Given this list of marker genes KRAS, HRAS, SOS1, GRB2, SOS2 (NCBI Gene Id 96829), RASSF1, EGFR, STK4, EGF, NRAS, RASSF5, here is a description of the gene set: species: Homo sapiens Pathway Definition from KEGG: EGF -> EGFR -> GRB2 -> SOS -> RAS -> (RASSF1+RASSF5) -> STK4 EGF-EGFR-RAS-RASSF1 signaling pathway. Pathway ID: N00096. Pathway type: Reference. Pathway class: nt06266 Non-small cell lung cancer. Human Gene Set: KEGG_MEDICUS_REFERENCE_EGF_EGFR_RAS_RASSF1_SIGNALING_PATHWAY